The following is a description of a gene set: Human Gene Set: GOBP_REGULATION_OF_CARDIOCYTE_DIFFERENTIATION species: Homo sapiens Any process that modulates the frequency, rate or extent of cardiocyte differentiation., and this is the list of marker genes: MIR145, SOX17, MIR133A1, TGFB1, EGFR, MIR222, NKX2-5, SMAD4, MYOCD, PRICKLE1, MEF2C, FZD7, SOX6, GPER1 (NCBI Gene Id 2852), WNT3A, KAT2A, MIR590, MIR200B, FRS2, TGFB2, DLL1, EFNB2, ARRB2, MIR204, BMP4 (NCBI Gene Id 652), DKK1, MIR1-1, BMP2, DHX36, TBX5, MIR499A, HDAC3, HEY2